Given this list of marker genes Eif1, Upf3a, Exosc10, Upf1, Upf3b, here is a description of the gene set: Any process that modulates the frequency, rate or extent of mRNA cis splicing, via spliceosome. studied in species Mus musculus Mouse Gene Set: GOBP_REGULATION_OF_MRNA_CIS_SPLICING_VIA_SPLICEOSOME